The following is a description of a gene set: Sparse or absent eyelashes studied in species Homo sapiens Human Gene Set: HP_SPARSE_OR_ABSENT_EYELASHES, and this is the list of marker genes: CWC27, TCOF1, ALX4, FIG4, DSC3, EDARADD, GTPBP2, DLX4, RECQL, EDNRA, MAP2K2, DPH5, JUP, NF1, KRT85, ANTXR1, FGF10, BANF1, PKP1, CST6 (NCBI Gene Id 1474), RECQL4, GJB2, FAM111B, LIPH, EDA, DOLK, SNRPE, VAC14, FRAS1, POLR1D, KRAS, CLDN1, MPLKIP, RNU12, CHD6, RNU4ATAC, NHP2, ODC1, ITGA3, POLR3A, LPAR6 (NCBI Gene Id 10161), GJA1, RIPK4, LTV1, ANAPC1, KRT74, TRPS1, PUM1, GJB6, RMRP, LMNA, NOP10, DSG4, ST14, SF3B4 (NCBI Gene Id 171), ZMPSTE24, HRURF, LSS, ALX1, TSR2, B4GALT7, TYMS, TWIST2, NECTIN4, LRP1, MAP2K1, RPL21, EBP, EDAR, APCDD1, IRX5, MBTPS2, BLM, HR, KREMEN1, DSP, POLR1C, COL11A1, TP63, KRT71 (NCBI Gene Id 112802), BRAF, SMARCA2, EPS8L3, HOXC13, WDR35, DKC1, SPINK5, PHGDH, KANK2, POLR1B (NCBI Gene Id 88998), SOX18, CDH3, DPH1, KRT25, NECTIN1